Given this list of marker genes CREM, RAB20, SLC4A7, MAP4K5, PLPP1, CA2, PDE4A, CAPN7, DDB2, IPCEF1, MTMR11, NR4A3, ARFGEF1, HBEGF, EFCAB14, THBD, NECAP1, BAX, TENT4A, CENPN, TNFRSF10B, FOSL2, ZNF451, SRSF1, ZMAT3, ENPP4, TRIM38, SEC24A, FRY, MFSD5, here is a description of the gene set: Human Gene Set: GAZDA_DIAMOND_BLACKFAN_ANEMIA_MYELOID_UP species: Homo sapiens Genes up-regulated in myeloid progenitor cells isolated from bone marrow of patients with Diamond-Blackfan anemia (DBA) and mutated RPS19. Diamond-Blackfan anemia (DBA) is a broad developmental disease characterized by anemia, bone marrow (BM) erythroblastopenia, and an increased incidence of malignancy. Mutations in ribosomal protein gene S19 (RPS19) are found in approximately 25% of DBA patients; however, the role of RPS19 in the pathogenesis of DBA remains unknown. Using global gene expression analysis, we compared highly purified multipotential, erythroid, and myeloid BM progenitors from RPS19 mutated and control individuals. We found several ribosomal protein genes downregulated in all DBA progenitors. Apoptosis genes, such as TNFRSF10B and FAS, transcriptional control genes, including the erythropoietic transcription factor MYB (encoding c-myb), and translational genes were greatly dysregulated, mostly in diseased erythroid cells. Cancer-related genes, including RAS family oncogenes and tumor suppressor genes, were significantly dysregulated in all diseased progenitors. In addition, our results provide evidence that RPS19 mutations lead to codownregulation of multiple ribosomal protein genes, as well as downregulation of genes involved in translation in DBA cells. In conclusion, the altered expression of cancer-related genes suggests a molecular basis for malignancy in DBA. Downregulation of c-myb expression, which causes complete failure of fetal liver erythropoiesis in knockout mice, suggests a link between RPS19 mutations and reduced erythropoiesis in DBA. from publication Gazda HT, Kho AT, Sanoudou D, Zaucha JM, Kohane IS, Sieff CA, Beggs AH (PMID 16741228)